Given this list of marker genes FCER1G, CD84, ADORA2B, SNAP23, MRGPRX2, FGR, VAMP3, PDPK1, MILR1, FCGR2B, VAMP7, PLA2G3, GPR15LG, AP1G1, LYN, PTGDS, SCN11A, NCKAP1L, KLRF2, VAMP2, RABGEF1, BCR, LAT2, STXBP3, GRP, UNC13D, KIT, IL13RA2, HCK, RAC2, CD300A, LAMP1, VAMP8, FCER1A, NKG7, STXBP2, S100A13, HLA-F, FES, PIK3CG, IL4R, PTGDR, CD160, ANXA3, RAB27A, CCL3, BTK, STX4 (syntaxin 4), FOXF1, STXBP1, F2RL1, LAT, IL13 (interleukin 13), SYK, FERRY3, SNX4, CEACAM1, CCR2, ITGAM, FCGR3A, CORO1A, PRAM1 (PML-RARA regulated adaptor molecule 1), CHGA, GATA2, CD177, CBL, SNX6, IGHE (immunoglobulin heavy constant epsilon), CLNK (cytokine dependent hematopoietic cell linker), ADGRE2, RAB44, PIK3CD, NR4A3, RASGRP1, SPHK2, ITGB2, LGALS9, GATA1, SPI1, CPLX2, GAB2, SLC18A2, KLRC2, here is a description of the gene set: studied in species Homo sapiens Human Gene Set: GOBP_LEUKOCYTE_DEGRANULATION The regulated exocytosis of secretory granules by a leukocyte.